Given this list of marker genes DUX4, DNMT3B, MAX, FRG1, LRP5, CTC1, TINF2, DUX4L1, SMCHD1, here is a description of the gene set: Exudative retinopathy species: Homo sapiens Human Gene Set: HP_EXUDATIVE_RETINOPATHY